Given this list of marker genes EHMT1, GRIA3, ARID1B, POGZ, DPYD, ASXL1, SH2B1, RSPRY1, AFG2A, TAF1, KMT2C, HERC1, here is a description of the gene set: Severe expressive language delay species: Homo sapiens A severe delay in the acquisition of the ability to use language to communicate needs, wishes, or thoughts. Human Gene Set: HP_SEVERE_EXPRESSIVE_LANGUAGE_DELAY